The following is a description of a gene set: studied in species Homo sapiens Genes down-regulated in CD4 T conv over-expressing IKZF2 versus IKZF2 and FOX3P. Human Gene Set: GSE40274_HELIOS_VS_FOXP3_AND_HELIOS_TRANSDUCED_ACTIVATED_CD4_TCELL_DN The transcription factor FoxP3 partakes dominantly in the specification and function of FoxP3+ CD4+ T regulatory cells (Tregs), but is neither strictly necessary nor sufficient to determine the characteristic Treg transcriptional signature. Computational network inference and experimental testing assessed the contribution of several other transcription factors (TFs). Enforced expression of Helios or Xbp1 elicited specific signatures, but Eos, Irf4, Satb1, Lef1 and Gata1 elicited exactly the same outcome, synergizing with FoxP3 to activate most of the Treg signature, including key TFs, and enhancing FoxP3 occupancy at its genomic targets. Conversely, the Treg signature was robust to inactivation of any single cofactor. A redundant genetic switch thus locks-in the Treg phenotype, a model which accounts for several aspects of Treg physiology, differentiation and stability. from publication Fu W, Ergun A, Lu T, Hill JA, Haxhinasto S, Fassett MS, Gazit R, Adoro S, Glimcher L, Chan S, Kastner P, Rossi D, Collins JJ, Mathis D, Benoist C (PMID 22961053), and this is the list of marker genes: HIVEP3, CACNG4, HDAC5, AGK, IPP, SUSD6, ENTPD5, ENDOU, PPM1F, ZNF629, DUSP12, SLC12A5, TSEN2, SMAD1, MINDY3 (MINDY lysine 48 deubiquitinase 3), TMEM164, PAG1, SATB1 (NCBI Gene Id 6304), ACAT1, XPO1, ZNF330, TMCC3, POP1, ACTR2, RNF113A, RAP1A, CEP41, MSL2, EXOC5, ATP23, GBP2, NRGN, ITGB3, RBM15B, SAG, ZNF799, VOPP1, MORF4L2, CD247, SEMA4A, BACH2, MYL10, CD84, IQCG, FXYD5, PLXND1, CPM, ZNF597, DET1, CENPJ, DPH6, COL23A1, SCOC, KLK8, TBL1X, EXTL3, LAT, ARHGAP29, QRICH1, SCML4, TMEM185A, EPHX4, CMC2, IL1RL2, RCBTB1, MCTP2, USP12, METTL2B, UTP4 (UTP4 small subunit processome component), ZNF623, RUNX3, NCBP1, COL1A2, SPPL2A, CORO1C, TMEM53, BACE1, FLOT2, PGGT1B, LNPK, KBTBD7 (NCBI Gene Id 84078), CCAR2, PLCE1, IL1RAPL1, GPATCH4, TSNAX, EFNA4, LXN, HSPA1B, ZBED4, ID2, CDYL, PHF20, PJA1, CTPS1, PXYLP1, SLC16A10, MBOAT1, ZNF22, RCBTB2, SEPTIN9, HSDL1, EPHB6, IPO11, LYPD6B, IL21, PACSIN1, CLIC1, PDLIM5, WDR45B, ABI3, CNGA1, COL6A2, TET1, AFP, F2R, PXMP4, SPRYD4, CRTAM, ATP6V0A2, ZNF467, BUD23, ENG, SSBP4, MPDU1, CCR9, OXCT1, ANTXR2, MTAP, KHDRBS3, NAA16, CSNK1G2, TDRKH, CKB, PACS2, ACP5, ZNF770, LEF1, LINC01160, EMILIN1, RAB35, SSR1, QPCT, ITPR1, SLC9A9, MYL11, TGFBR3, IKZF1, DTX2, PDXK, TCF20, RPH3AL, LPAR6, DGLUCY, MRPL19, SDE2, TMEM59L, SALL2, TM6SF1, DENND11, DNTTIP1, USP36, SLC39A14, HAUS4, ZRSR2, MPHOSPH6, NDC1, SGPL1, TSPYL4, SLC39A11, SEPSECS, REPIN1, CHMP6, INPP1, ACOT7, ARHGEF6, CEP78, SPSB1 (splA/ryanodine receptor domain and SOCS box containing 1), DZIP1 (NCBI Gene Id 22873), BPGM, PPRC1, AGFG2, PITRM1, ROBO1, TMIE, PDE3B, PLCB2, SHC1, ITGA8, SNX30, ARMC7, ST3GAL6, H19, PGLYRP2, IFT57, SSNA1, IGFBP4, PTGFRN (NCBI Gene Id 5738), CLTB